Given this list of marker genes GNG8, GNG2, PIK3CG, GNG12, GNB5 (NCBI Gene Id 82962), CXCR2, GNG7, GNGT1 (G protein subunit gamma transducin 1), PIK3R6, GNG10, GNG5, GNG13, GNB1, GNB3, GNG3, GNG4, GNGT2, AKT1, MTOR, AKT2, GNB2, CXCL8, GNB4, PIK3R5, AKT3, GNG11, here is a description of the gene set: CXCR-GNB/G-PI3K-AKT signaling pathway. Pathway ID: N00154. Pathway type: Reference. Pathway class: nt06224 CXCR signaling. Pathway Definition from KEGG: CXCL8 -> CXCR2 -> GNB/G -> PI3Kgamma -> PIP3 -> AKT -> MTOR Human Gene Set: KEGG_MEDICUS_REFERENCE_CXCR_GNB_G_PI3K_AKT_SIGNALING_PATHWAY studied in species Homo sapiens